Given this list of marker genes GATA1, RPL9, HEATR3, RPL35A (NCBI Gene Id 6165), RPL11, RPL35, RPL18, RPL26, RPL31, RPS24, RPS17, EPO, RPS20, RPS15A, RPS19, TSR2, PNP, RPS26, RPS28, RPL15, RPS27, RPS7, RPS10, CTLA4, RPL8, RPS29, TP53, RPL5, ADA2, RPL27, here is a description of the gene set: Human Gene Set: HP_PURE_RED_CELL_APLASIA Pure red cell aplasia A type of anemia resulting from suppression of erythropoiesis with little or no abnormality of leukocyte or platelet production. Erythroblasts are virtually absent in bone marrow; however, leukocyte and platelet production show little or no reduction. studied in species Homo sapiens